Given this list of marker genes CTSA (NCBI Gene Id 5476), SNCA (synuclein alpha), SNRNP70 (NCBI Gene Id 6625), ATP13A2, STUB1, LAMP2, ATG5, EEF1A1, HSP90AA1, EEF1A2, HSPA8, BAG3, PLK3, GFAP, CLU, here is a description of the gene set: studied in species Homo sapiens Human Gene Set: GOBP_CHAPERONE_MEDIATED_AUTOPHAGY The autophagy process which begins when chaperones and co-chaperones recognize a target motif and unfold the substrate protein. The proteins are then transported to the lysosome where they are degraded.